Given this list of marker genes SHPK, MYF6 (myogenic factor 6), SLC27A4, ALDH7A1, BIN1, HSD3B2 (hydroxy-delta-5-steroid dehydrogenase, 3 beta- and steroid delta-isomerase 2), RNF168, DNM2, PLPBP, MED12, GALK1, MTMR14, COG7, RYR1, here is a description of the gene set: species: Homo sapiens Respiratory failure in the newborn. Human Gene Set: HP_NEONATAL_ASPHYXIA Neonatal asphyxia